Given this list of marker genes SNRNP35, STX3, ZNF117, ITGA6 (NCBI Gene Id 3655), E2F3, DDIT4, STXBP3, RND3, GREM1, ASPH, WEE1, DUSP1, CASP3, TOPBP1, NOP16, GEM, PHTF2, here is a description of the gene set: from publication Gentile M, Latonen L, Laiho M (PMID 12907719) species: Homo sapiens DNA damage caused by UV radiation initiates cellular recovery mechanisms, which involve activation of DNA damage response pathways, cell cycle arrest and apoptosis. To assess cellular transcriptional responses to UVC-induced DNA damage we compared time course responses of human skin fibroblasts to low and high doses of UVC radiation known to induce a transient cellular replicative arrest or apoptosis, respectively. UVC radiation elicited >3-fold changes in 460 out of 12,000 transcripts and 89% of these represented downregulated transcripts. Only 5% of the regulated genes were common to both low and high doses of radiation. Cells inflicted with a low dose of UVC exhibited transcription profiles demonstrating transient regulation followed by recovery, whereas the responses were persistent after the high dose. A detailed clustering analysis and functional classification of the targets implied regulation of biologically divergent responses and suggested involvement of transcriptional and translational machinery, inflammatory, anti-proliferative and anti-angiogenic responses. The data support the notion that UVC radiation induces prominent, dose-dependent downregulation of transcription. However, the data strongly suggest that transcriptional repression is also target gene selective. Furthermore, the results demonstrate that dose-dependent induction of cell cycle arrest and apoptosis by UVC radiation are transcriptionally highly distinct responses. Human Gene Set: GENTILE_UV_RESPONSE_CLUSTER_D1 Cluster d1: genes down-regulated in WS1 cells (fibroblast) at 6 h after irradiation with high dose UV-C.